The following is a description of a gene set: Mouse Gene Set: CUI_MAST_CELL_NOGGIN_RESPONSE_UP studied in species Mus musculus Cytokines mediate cell-cell communication in the immune system and represent important therapeutic targets. A myriad of studies have highlighted their central role in immune function, yet we lack a global view of the cellular responses of each immune cell type to each cytokine. To address this gap, the authors created the Immune Dictionary, a compendium of single-cell transcriptomic profiles of more than 17 immune cell types in response to each of 86 cytokines (>1,400 cytokine-cell type combinations) in mouse lymph nodes in vivo. A cytokine-centric view of the dictionary revealed that most cytokines induce highly cell-type-specific responses. For example, the inflammatory cytokine interleukin-1β induces distinct gene programmes in almost every cell type. A cell-type-centric view of the dictionary identified more than 66 cytokine-driven cellular polarization states across immune cell types, including previously uncharacterized states such as an interleukin-18-induced polyfunctional natural killer cell state. Genes positively differentially expressed in cell type: Mast cell upon treatment with cytokine: Noggin in mouse lymph nodes in vivo. from publication Cui A, Huang T, Li S, Ma A, Pérez JL, Sander C, Keskin DB, Wu CJ, Fraenkel E, Hacohen N (PMID 38057668), and this is the list of marker genes: Cstf1, Fam171a1, Ctps1, Armc5, Tmem44, Hpgd